The following is a description of a gene set: Human Gene Set: GOMF_VITAMIN_D_BINDING Binding to vitamin D, any of a group of related, fat-soluble compounds that are derived from delta-5,7 steroids and play a central role in calcium metabolism. Specific forms of vitamin D include calciferol (ergocalciferol; vitamin D2) and cholecalciferol (calciol; vitamin D3). studied in species Homo sapiens, and this is the list of marker genes: KL, CYP2R1, IRX5, S100G, VDR, GC (GC vitamin D binding protein), CALB1